Given this list of marker genes C1QTNF1, AGT, REN, KCNK9, DAB2, WNK4, BMP6, AGTR1, here is a description of the gene set: species: Homo sapiens The regulated release of aldosterone into the circulatory system. Aldosterone is a pregnane-based steroid hormone produced by the outer-section (zona glomerulosa) of the adrenal cortex in the adrenal gland, and acts on the distal tubules and collecting ducts of the kidney to cause the conservation of sodium, secretion of potassium, increased water retention, and increased blood pressure. The overall effect of aldosterone is to increase reabsorption of ions and water in the kidney. Human Gene Set: GOBP_ALDOSTERONE_SECRETION